Given this list of marker genes Abl1, Gsn, Abl2, Ripor2, Dock8, Flot2 (flotillin 2), here is a description of the gene set: studied in species Mus musculus Mouse Gene Set: GOBP_REGULATION_OF_ESTABLISHMENT_OF_T_CELL_POLARITY Any process that modulates the frequency, rate or extent of establishment of T cell polarity.